Given this list of marker genes Cltc, Ezr, Mapk1, Msn (moesin), Actg1, Tubb6, Tuba3a, Tuba1b, Ap2a1, Tuba8, Tubal3, Tubb4a, Src, Numb, Tubb4b, Dpysl2, Tubb2b, Sh3gl2, Tubb2a, Tuba1a, Tuba4a, Kif4, Ap2m1, Tubb3, Clta, Tuba1c, Ap2s1, Ap2a2, Tubb1, Dnm2, Rdx, Actb, Dnm1 (dynamin 1), Tuba3b, Ap2b1, Dnm3, here is a description of the gene set: studied in species Mus musculus Recycling pathway of L1 Mouse Gene Set: REACTOME_RECYCLING_PATHWAY_OF_L1